The following is a description of a gene set: Human Gene Set: JIANG_MELANOMA_TRM8_CD4 from publication Jiang C, Chao CC, Li J, Ge X, Shen A, Jucaud V, Cheng C, Shen X (PMID 38455971) Tissue-resident memory T cells (TRM) are a specialized T cell population residing in peripheral tissues. The presence and potential impact of TRM in the tumor immune microenvironment (TIME) remain to be elucidated. Here, we systematically investigated the relationship between TRM and melanoma TIME based on multiple clinical single-cell RNA-seq datasets and developed signatures indicative of TRM infiltration. TRM infiltration is associated with longer overall survival and abundance of T cells, NK cells, M1 macrophages, and memory B cells in the TIME. A 22-gene TRM derived risk score was further developed to effectively classify patients into low- and high-risk categories, distinguishing overall survival and immune activation, particularly in T cell-mediated responses. Altogether, our analysis suggests that TRM abundance is associated with melanoma TIME activation and patient survival, and the TRM-based machine learning model can potentially predict prognosis in melanoma patients. studied in species Homo sapiens, and this is the list of marker genes: ANKRD12, YPEL5, RPL4, CORO1A (coronin 1A), FYB1, ZFAS1, ARHGEF1, REX1BD, CIB1, FOS, TRBC2, SCML4, GATA3, MALAT1, N4BP2L2, RPSA, RPS15A, TRAT1, LCP1, STOM, THEMIS, TSC22D3, TNFAIP8, RPS28, MT-ATP6, STK4 (NCBI Gene Id 6789), RPS12, RPL30, BTG1, CAST, ANXA2, DUSP1, MYADM, PBXIP1, MT-ND5, TMA7, RPL39 (ribosomal protein L39), OSTF1, IVNS1ABP, RPL35, RPL17, LINC00513, CD247, CD5, GNG2, UQCR11, ARRB2 (arrestin beta 2), TC2N (NCBI Gene Id 123036), CD40LG, COX7C, CCND3, LAPTM5 (lysosomal protein transmembrane 5), SELENOW, YWHAQ, RPS14, SKP1, PPP1R15A, CD28, SKAP1, SYTL3, RPL14, PIM1, RPS3A, RPL38, RPL34, NOSIP, APRT, MT-ND3, SUN2, PPIA, RPS8, MGAT4A, RPL32, RPS21, TRBC1, HLA-E, SPSB3, CCDC107, PFN1, CSRNP1, ID2, PPDPF, CCDC85B, KLRB1, BTG2, CDC42SE2, ABRACL, IFITM1, DENND2D, RPLP1, ZAP70, RPL5, MT-ND2, GIMAP7, NDUFS5 (NADH:ubiquinone oxidoreductase subunit S5), CFL1, LYSMD2, TBCB, RPS5, RSRP1 (arginine and serine rich protein 1), RPS27, VSIR, RBMS1, HSP90AA1, RPS15, PEBP1, IL10RA, MYL12A, SF1, HNRNPDL, MT-ND1, CNBP, CYTIP, CDKN1B, PHLDA1, SLFN5, OXNAD1, VIM, RGCC, MIF, DDX24, PSME1, PA2G4, EEF1D, ARHGDIB, PDCD4, HLA-F, MT-CYB, IKZF1, RPS4Y1, HSPA1B, SDCBP, LY6E, RPL10A, CDK17, SMAP1, FOSB, PHF20, CCND2, ZFP36, MT-ATP8, TRAF3IP3, RPS13, CHURC1, PDLIM2, EEF1G, IFNGR1, CD3E, CD96, IDS, S100A6, IL32 (interleukin 32), IL2RG, MT-ND4L, SELPLG, PABPC1, ARHGAP15, SLC2A3, SIGIRR, PRNP, BTF3 (NCBI Gene Id 689), CD99, UBA52, SARAF, ANAPC16, GIMAP1, RPL37A, RPS2 (NCBI Gene Id 6187), POLR1H, EIF4A2, NR4A2, EIF3E, PPP2R5C, C9orf78 (chromosome 9 open reading frame 78), RPL11, S100A11, MT-CO1, PTGES3, RPS9, CDC42EP3, BCAP31, TAGLN2, RPS27A, CMPK1, MICOS10, RPS23, ZFP36L1, PTGER4, ITM2B, CLEC2D, RPL7, MZT2B, LCK, HNRNPUL1, GPR183, ICAM2, MBNL1, ANXA1, SYNE2, NACA, EGR1, ENO1, RPS26, ARL4C, PFDN5, CAMK4, CD3G, CD6, TRIM22, RGS2, TMEM35B, PSIP1, TAF7 (NCBI Gene Id 93080), GLIPR1, MYH9, RPL21, RPLP0, PRMT2 (protein arginine methyltransferase 2), DDX3X, PNRC1, ZFP36L2, RPL26, RPL37, PARP8, HLA-A, ODF2L, RPL35A, ARL4A, SPN, RPL9, PPP1R2, ETS1, MCL1, HNRNPA2B1, EIF1, RPS19, GMFG, RORA, TOMM7, SOD1, FXYD5, ITM2A, RPL36A, LCP2, DHRS7, COMMD6, RPL27A, AHNAK, SNRPD2, SH3BGRL3, S100A4, CD4, RPS18 (ribosomal protein S18), RBL2, RPL24, CORO1B, TXNIP, HNRNPA1, IL27RA, ICOS, CD48 (CD48 molecule), RPS3, EML4, IL7R, FTH1, RPS29, H3-3B, CYCS, EMP3, EVL, NPM1, SNHG8, GSTK1, DNAJB1, TUBA1A, CD69, YWHAH, NFKBIZ, LGALS3, NFKBIA, TRAPPC6A, TLE5, RGS14, HNRNPA0, MZT2A, RPL13A, DAZAP2, STING1, EEF1A1, FUS, GLIPR2, ARHGDIA, RPL8, RPL36, SRSF7, TUBA4A, SPOCK2, GADD45B, EVI2A, RPS7, RESF1, RPS20, PAXX, CRIP1, SIT1, APBB1IP, HSPA8, TMSB4X, DDIT4, RPS17, SH2D2A, PTPRC, RBMX, EEF1B2, NCL, PIK3R1, JUNB, ATP1A1, GPSM3, INPP4B, RPL28, NOP53, S100A10, PGK1, IFITM2, CALM1, YWHAZ (NCBI Gene Id 83242), LTB, CDC37, CREM, CXCR4, RPL6, UQCRB, CITED2, SLAMF1, RPS24, CLDND1, ARPC1B, FAU (NCBI Gene Id 55430), RPL29, KLF6, NR4A1, CKLF, M6PR, ACAP1, CD2, RPL19, AQP3, RPL27, RPL13, PTGER2, TPT1, GIMAP4, ADGRE5, ZC3HAV1, MT-CO3, HINT1, SRGN, GIMAP2, RPS10, PTPRCAP, RPS4X, RPL22, EIF4B, MYL12B, JUN, RPL31, RPS6, TNFAIP3, CD3D, C12orf57, MCUB, LRRFIP1, LDHB, RPS25, RPS16 (ribosomal protein S16), RPL23A, NME3, B2M, EMB, DDX5, TTC39C, ARL6IP5, LEPROTL1, HLA-B, PLP2, PPA1, RPL12, CD44, DNAJA1, HCST, TMEM123, LAT, RAP1B, SAMSN1, HMOX2, ERN1, RPL10, LDHA (NCBI Gene Id 3939), CXCR3, TPM3, ST3GAL1, RPL36AL, RPLP2, RPL3, FLT3LG, CMTM3, TNF, STAT4, GZMM, RPL7A, RPL18A, TAGAP, PNP, RGL4, JAML, RPL18, TOMM20, DYNLT3, STAT1, RNF149, SOCS1, RCAN3, JUND, NDFIP1 (Nedd4 family interacting protein 1), TRADD